The following is a description of a gene set: A tubular array of microtubules that extends from the perinuclear ring surrounding the spermatid nucleus to the flagellar axoneme. The manchette may also contain F-actin filaments. Mouse Gene Set: GOCC_MANCHETTE studied in species Mus musculus, and this is the list of marker genes: Actr1a, Spag17, Ift20, Spef2 (NCBI Gene Id 320277), Spag6l, Cfap221, Ccdc181, Ppp1r42, Iqcg, Ran, Pacrg, Rimbp3, Stk33, Spmip6 (sperm microtubule inner protein 6), Dync1h1, Ift88, Snapin (NCBI Gene Id 99847), Lrguk (leucine-rich repeats and guanylate kinase domain containing), Cfap53, Cfap70, Lztfl1, Ccdc42, Meig1, Cep131, Odf1, Strbp, Ccdc38